The following is a description of a gene set: studied in species Mus musculus Mouse Gene Set: GOBP_CYTOLYSIS The rupture of cell membranes and the loss of cytoplasm., and this is the list of marker genes: Ccl28, Gbp7, Gbp2b, Gbp2 (NCBI Gene Id 14469), Ninj1, Gbp3, Igtp, Camp, Gbp5, Rraga